Given this list of marker genes Rtkn, Arhgef12 (NCBI Gene Id 69632), Rhob, Pik3r2, Depdc1b, Arhgef1, Vangl1, Actc1, Ophn1, Stard13, Stard8, Stk10, Pcdh7, Mcam, Arhgdig, Cav1, Arhgef10l, Arhgef10, Dlc1, Arhgef3, Jup, Flot1, Arhgap26, Prex1, Pkn1, Flot2, Racgap1, Arhgef17, here is a description of the gene set: Reactome Pathway: RHOB GTPase cycle This event has been computationally inferred from an event that has been demonstrated in another species.<p>The inference is based on the homology mapping from PANTHER. Briefly, reactions for which all involved PhysicalEntities (in input, output and catalyst) have a mapped orthologue/paralogue (for complexes at least 75% of components must have a mapping) are inferred to the other species. electronically inferred by orthology from the curated human pathway part of: RHO GTPase cycle species: Mus musculus